The following is a description of a gene set: Human Gene Set: GOMF_PROTEIN_CARBOXYL_O_METHYLTRANSFERASE_ACTIVITY species: Homo sapiens Catalysis of the transfer of a methyl group to a carboxyl group on a protein., and this is the list of marker genes: ARMT1, LCMT1, PCMT1, ICMT, PCMTD1, PCMTD2